The following is a description of a gene set: species: Mus musculus Any process that stops, prevents or reduces the frequency, rate or extent of calcium ion transmembrane transporter activity. Mouse Gene Set: GOBP_NEGATIVE_REGULATION_OF_CALCIUM_ION_TRANSMEMBRANE_TRANSPORTER_ACTIVITY, and this is the list of marker genes: Gstm7, Casq2, Gpr35, Pln, Cacna1f, Gsto1, Zfas1, Calm1, Dysf, Sri, Fmr1, 1810037I17Rik, Sln, Calm3, Smim6, Tlr9, Drd2, Drd4, Pkd2, Cbarp, Mrln, Ubqln1, Gnb5, Calm2